The following is a description of a gene set: Lipoatrophy species: Homo sapiens Localized loss of fat tissue. Human Gene Set: HP_LIPOATROPHY, and this is the list of marker genes: SAMHD1, DSG2, PSEN2, HAND2, JPH2, PLAAT3, GATAD1, TXNRD2, GET3, MYH7, TAF1A, DMD, ACTN2, POLR3A, TNNT2, TNNC1, LSM11, TMPO, TREX1, MYPN, LMOD2, CLMP, SCN5A, LMNA, TAFAZZIN, CSRP3, RPL3L, LDB3 (NCBI Gene Id 1219), FBN1, PPCS, CAP2, RBM20, RNASEH2B, PLN, TPM1, ACTC1, SLC25A24, ABCC9, PLIN1, SGCD, DOLK, RAF1, RBM28, PSEN1, DSP, VEZF1, TCAP, RNASEH2A, DES, ACTB, TTN, PIK3R1, SDHA, FUCA1, FLNA, PIK3CA, BANF1, MYH6, PRDM16, FKTN, ANKRD1, FHL2, LAMA4, RNU7-1, VCL, IFIH1, RNASEH2C, BAG5, MYBPC3, PPARG (peroxisome proliferator activated receptor gamma), LMNB2, WRN, PDGFRB, CRYAB, TNNI3, ADAR, BAG3, COL3A1, NEXN